The following is a description of a gene set: Human Gene Set: GOCC_MEMBRANE_MICRODOMAIN studied in species Homo sapiens A membrane region with a lipid composition that is distinct from that of the membrane regions that surround it., and this is the list of marker genes: PTCH1, CHRNB2 (cholinergic receptor nicotinic beta 2 subunit), CD14, ABCB4, DLL1, KIF18A, KCNQ1, CD177, CD19, ARC, MYO1C, CAVIN2, BVES, TLR6, CAV2, S1PR1, DPP4, CTNNA1, CLIP3, TNFRSF1A, VDAC1, SYNJ2, LRRK2, THY1, SLC2A1, ANGPT1, GJA1, TNFRSF10A, EGFR, INSR, LYPD4, PDPN, GHSR, PIKFYVE, MYOF, RGMB, KDR, SRC, EEIG1, SLC6A3, GP6, TRAF2, PAG1, ASAH2, TREM2, CHP1, EZR, ANXA2, TPP1, CD48, SELPLG, CLN6, TNFRSF11A, CD244, PLPP2, GPRC5B, ADCY2, TFPI, STIM1, RFTN1, MAL (mal, T cell differentiation protein), MYO1A, SGCA, VCL, BST2, TLR2, TUBB, SORBS1, DLG1, RTN4R, TNF, PSEN1, PRKAR1A, PPP2CA, IKBKB, EHD2, CBLC, PPP2R1B, PLCG2, TNFRSF1B, FAIM2, SMO, FXYD1, HK1, LRP4, FYB2, PI4K2A, KCND2, CALHM1, SLC9A1, SMPD2, ADGRG1, HYAL2, EMP2, RIT2, SERPINH1, NPC1, PARK7 (NCBI Gene Id 113880), CDH15, MLC1, DLC1, APP, ACE2, MYADM, ATP1A2, ATP5F1A, CAVIN3, CAVIN4, NFAM1, F2R, MS4A4A, LCK, RAP1B, ICAM1, SELE, GLIPR1L1, FAS, OLR1 (NCBI Gene Id 4973), PLPP1, SLC6A4 (NCBI Gene Id 6532), PGK1, ATP2B4, ENTPD1, ZAP70, SLC22A6, BTK, ADCY8, SPRED1, STOML3, SHH, LAMP2, SDCBP (syndecan binding protein), UNC5A, GP2, HAS2, PODXL (podocalyxin like), CD79A, CDH13, DAG1, SLC39A6, STOML2, LYPD6, MALL (mal, T cell differentiation protein like), ATP1A1, NEU3, AKAP5, FLOT2, NTSR1, CD4, BACE1, FASLG, CD24, ADRA1A, TRPM8, GPM6B, STX12, RANGRF, ATP1A4, CD36, P2RX1, LDHB, ANXA13, SULF1, HTR2A, PRNP, MME, AKAP6, TGFBR2, CD55, BEST1, MAPK1, ADCYAP1R1, PECAM1, LCP2, LRP8, CD8A, FYN, EFHD2, GASK1A, FLOT1, HCK, PLSCR1, TEK, S100A10, ADAM17, CHRNA3, ADD2 (adducin 2), CD226, CDH1, TLR1, ADCY1, TNR, EFNA5, PTGIS, GPC1 (NCBI Gene Id 2817), SLC1A1, CORO1C, IL6ST (interleukin 6 cytokine family signal transducer), PLPP3, KCNA5, CDH2, SMURF2, KCNMA1, MAPK3, STOM, PRKACA, CBLB, LRP6, ABCG2, BAALC, NOS1AP, LAX1, NOS1, EPHB1, PLLP, NPHS2, SCN5A, CBL, RAP2B, CAV3, LIPE, CR1, PRTN3, AHNAK, ERLIN1, JAK2, CNR1, KCNE1, TGFBR1, GAB2, RTN4RL1, ITGAM, STOML1, INPP5D, CAPN2, RAB5A, CTSD, CRIPTO, MAPT, CLN3, CHRNA7, ERLIN2, LAT2, CXADR, TRPC4, BMPR2, MAG, HDAC6, IRS1, SLC1A2, LAT, KCNE3, CARD11, MS4A1, PRKAR2A, LYN, LAMTOR1, DMD, EFNB1, MAL2, RHOQ, PROM2 (prominin 2), TEX101, PACSIN2, RTN4RL2, HPSE, BMPR1A, ENO2, VDAC2, BCL10, FURIN, ATP1B1, ARID3C, CTNNB1, SCARB1, CD1A, ITGB2 (NCBI Gene Id 3689), ARID3A, NOS3, LY6K, ITLN1, CAV1, SLC2A4, PPT1 (palmitoyl-protein thioesterase 1), ADRA1B, CAVIN1, ITGB1, ORAI1, UNC5B (NCBI Gene Id 23663), PTPRC (protein tyrosine phosphatase receptor type C), ABCA1, ADTRP, PLVAP, SKAP1